The following is a description of a gene set: from publication Mikkelsen TS, Hanna J, Zhang X, Ku M, Wernig M, Schorderet P, Bernstein BE, Jaenisch R, Lander ES, Meissner A (PMID 18509334) Somatic cells can be reprogrammed to a pluripotent state through the ectopic expression of defined transcription factors. Understanding the mechanism and kinetics of this transformation may shed light on the nature of developmental potency and suggest strategies with improved efficiency or safety. Here we report an integrative genomic analysis of reprogramming of mouse fibroblasts and B lymphocytes. Lineage-committed cells show a complex response to the ectopic expression involving induction of genes downstream of individual reprogramming factors. Fully reprogrammed cells show gene expression and epigenetic states that are highly similar to embryonic stem cells. In contrast, stable partially reprogrammed cell lines show reactivation of a distinctive subset of stem-cell-related genes, incomplete repression of lineage-specifying transcription factors, and DNA hypermethylation at pluripotency-related loci. These observations suggest that some cells may become trapped in partially reprogrammed states owing to incomplete repression of transcription factors, and that DNA de-methylation is an inefficient step in the transition to pluripotency. We demonstrate that RNA inhibition of transcription factors can facilitate reprogramming, and that treatment with DNA methyltransferase inhibitors can improve the overall efficiency of the reprogramming process. Genes up-regulated in partially reprogrammed and pluripotent cell populations (induced, iPS; and embryonic stem cells, ES) compared to parental lineage-commited cell lines. Mouse Gene Set: MIKKELSEN_DEDIFFERENTIATED_STATE_UP studied in species Mus musculus, and this is the list of marker genes: Fbxo15, Fgf4, Etv5, Zic3, Jarid2, Cobl (NCBI Gene Id 211381), Phc1, Dsg2